The following is a description of a gene set: The process in which a precursor cell type acquires the specialized features of a pro-B cell. Pro-B cells are the earliest stage of the B cell lineage and undergo heavy chain D and J gene rearrangements, although they are not fully committed. Human Gene Set: GOBP_PRO_B_CELL_DIFFERENTIATION studied in species Homo sapiens, and this is the list of marker genes: HES5 (hes family bHLH transcription factor 5), HES1, FLT3, SOS1, NUDT21, SOS2, SOX4, LIG4, FNIP1, PRKDC, NOTCH1, FLCN